Given this list of marker genes RNASE13, PPP1R1B, SLC25A14, POLR1D, STRADA, PMEL, MEF2D, SMAD6, MPZ, SCUBE3, SLC25A42, SGTA, MTCL2, NAV1, SOX10, KCNK15, ATAT1, GRM3, SPRED3, RING1 (NCBI Gene Id 6015), GIPC3, INAVA, DYRK1B, ZNF853, CNN1, ELOA, RFX4, CDC42EP1, DUSP9, SNX29, MED19, SEPTIN5 (NCBI Gene Id 5413), SLC8A2, CLEC4D, WBP4, RUSC2 (RUN and SH3 domain containing 2), S1PR2, CRISP2, GPR3, SMYD5, SLC34A2, BMP1, CPLX2, CRYZ, MNT, FAM131B, NCDN, CLVS1, PAX2, SORCS2, NAA40, ABTB2, SEPTIN9, RERE, ARFIP1, SDC3 (NCBI Gene Id 9672), RNF111, PHLPP1, ZNF704, CNTNAP1, EFCAB13, TSPAN11, MECP2, NECTIN1, PEX5, MAP1A, COL4A1, PABPC4, GRIK5, GATAD2B, NFIX, PAX8, PPP1CA, TNRC18, NUTM2A, SRCIN1, DAGLA, DPY19L1, ASAP1, RFX3, RBFOX2, NUTM2B, NHLH1, SLC12A7, HIF3A, NAPA, INKA2, SPN (sialophorin), LZTS3, PPP1R9B, CASTOR2, WNT7A, here is a description of the gene set: from publication Chen Y, Wang X (PMID 31504780) Genes predicted to be targets of miRBase v22 microRNA hsa-miR-637 in miRDB v6.0 with MirTarget v4 prediction scores > 80 (high confidence targets). species: Homo sapiens Human Gene Set: MIR637